Given this list of marker genes ATF5, TACSTD2, VSIG10, VPS26B, HMGN4, ARRB1, RAP1GDS1, SIRPA, SS18L2, SCARA3, MYCL, ERO1A, NPDC1, ADGRF5, PPP2R1B, SAPCD2, RARA (retinoic acid receptor alpha), CARNMT1, RASSF2, MEA1, CDK2, IGFBP6, here is a description of the gene set: Human Gene Set: YORDY_RECIPROCAL_REGULATION_BY_ETS1_AND_SP100_UP SP100 was first identified as a nuclear autoimmune antigen and is a constituent of the nuclear body. SP100 interacts with the ETS1 transcription factor, and we have previously shown that SP100 reduces ETS1-DNA binding and inhibits ETS1 transcriptional activity on the MMP1 and uPA promoters. We now demonstrate that SP100 expression is upregulated by interferons, which have been shown to be antiangiogenic, in primary endothelial cells. As ETS1 is functionally important in promoting angiogenesis, we tested the hypothesis that ETS1 activity is negatively modulated by SP100 in endothelial cells. SP100 directly antagonizes ETS1-mediated morphological changes in human umbilical vein endothelial cell (HUVEC) network formation and reduces HUVEC migration and invasion. To further understand the functional relationship between ETS1 and SP100, cDNA microarray analysis was utilized to assess reprogramming of gene expression by ETS1 and SP100. A subset of the differentially regulated genes, including heat-shock proteins (HSPs) H11, HSPA1L, HSPA6, HSPA8, HSPE1 and AXIN1, BRCA1, CD14, CTGF (connective tissue growth factor), GABRE (gamma-aminobutyric acid A receptor epsilon), ICAM1, SNAI1, SRD5A1 (steroid-5-alpha-reductase 1) and THY1, were validated by real-time PCR and a majority showed reciprocal expression in response to ETS1 and SP100. Interestingly, genes that are negatively regulated by ETS1 and upregulated by SP100 have antimigratory or antiangiogenic properties. Collectively, these data indicate that SP100 negatively modulates ETS1-dependent downstream biological processes. species: Homo sapiens Genes up-regulated in HUVEC cells (endothelium) by ETS1 which were down-regulated by SP100. from publication Yordy JS, Moussa O, Pei H, Chaussabel D, Li R, Watson DK (PMID 15592518)